The following is a description of a gene set: Reactome Pathway: Erythropoietin activates Phosphoinositide-3-kinase (PI3K) part of: Signaling by Erythropoietin PI3K can bind the activated EPO receptor (EPOR) by three different mechanisms: direct binding to phospho-Y479 of the EPOR, indirect binding via phosphorylated IRS2 bound to the EPOR, and indirect binding via phosphorylated GAB1 bound to the EPOR. PI3K phosphorylates phosphatidylinositol 4,5-bisphosphate to yield phosphatidylinositol 3,4,5-trisphosphate which recruits AKT1 to the membrane. species: Homo sapiens, and this is the list of marker genes: EPO, JAK2 (NCBI Gene Id 3717), IRS2, PIK3CG, GAB1, PIK3CD, PIK3CB, PIK3CA, PIK3R1, LYN, EPOR, PIK3R5